Given this list of marker genes TBK1, GPD2, NETO2, TNIP3, BRCA1, NDRG1, DHRS7, NF1 (NCBI Gene Id 646021), IL10RA, FNBP1, ITGB1, AKIP1, DENND10, STT3B, RAB5A, LRP4, KSR2, SOS1, CALHM2, CBFB, KLF11, PARPBP, GLCCI1, FBP1, TAB2, ADAMTS3, IL10RB-DT, PERP, KAT2B, B3GNT5, WBP11, RAB11FIP1 (NCBI Gene Id 80223), PPP1R3D, HIKESHI, DNASE1L1, ERI2, SOCS2, GSTA4, ATP2C1, PPIH, CMTM6, INHBC, CCR6, NME7 (NME/NM23 family member 7), CDKN2B, MARCHF6, PKD2, CISH, PTGR1, PPP4R3A, SYNE3, FCRL3, HIP1, EOGT, CLPTM1L, TOX, KCNK6, TBC1D8, TNFSF13, CRCP, EVI5, ZC2HC1A, TBC1D22B, SEC16A, RDH10, ITGAL, DENND11, PIK3AP1, TMED8, STARD4, MAP4K3, PNPLA8, SAE1, IVNS1ABP, ARAP3, SDF4, UBE2E1, NME9, C2CD2, KCMF1, ADAM19 (NCBI Gene Id 8728), CXorf58, LY75, SGPP1, HYMAI (hydatidiform mole associated and imprinted), KLF9, HSPA1A, ANXA2, GOLIM4, KIT, ZNF788P, ANXA2P2, DPYSL2, TMEM87A, MEOX1, GNG10, CLDND1, PLN, HMGB3, MIR155HG, LAIR2, ZNF80, ATP6V1E1, RIC8B, SRXN1, SERP2, CTTN, ATP1B1, GPR63, VMP1, PLS3, PRF1, SAMSN1, C5, LRRC32, SRGAP2, INPP5F, SMS, CLNK, HLF, IKZF4, IGF2R, CERS5, FRMD6, SIAH2, PCTP, CYBB, PIM1, GINS2, DLG3, HLA-DRB1, MIR21, UTS2, LGALS3, KLHL2, MPST, UBR1, RBMS3, TAOK1, MIB1, MAP7, TOX2, SNX10 (NCBI Gene Id 29887), SPOPL, SERINC1, USP10, PGAM1, RDX, IRS2, CDK6, KSR1, BTNL9, INSL5, AMFR (NCBI Gene Id 267), HS3ST3B1, TMEM62, MED9, TNFRSF18, NABP1, ZPR1, CYP1A1, CHRNA3, IL2RB, TWIST1, ATP1B3, CEP72, MAP3K8, CLGN, MFN2, ENTPD1, NHS, ZBTB20-AS1, AGO4, TENT5C, EPAS1, TRUB1, CREB3L2, UGCG (NCBI Gene Id 7357), FANCL, FAM13A, APLP2, RAD21, HNRNPLL, DHRS3, PPP4R1, MBNL1 (NCBI Gene Id 9850), NEK3 (NCBI Gene Id 4752), CACYBP, PPP3CB, AHR, NFAT5, SLC1A4, PGM2L1, NUDT17, DDX50, DOCK5, TRIB1, MMD, here is a description of the gene set: Human Gene Set: GSE25087_TREG_VS_TCONV_FETUS_UP from publication Mold JE, Venkatasubrahmanyam S, Burt TD, Michaëlsson J, Rivera JM, Galkina SA, Weinberg K, Stoddart CA, McCune JM (PMID 21164017) Genes up-regulated in comparison of fetal regulatory T cell (Treg) versus fetal conventional T cells. We compared differences in fetal and adult T cells by performing whole genome profiling on sort-purified T cells (naïve CD4+ and Treg cells) from human fetal specimens (18-22 gestational weeks) and adult specimens (age 25-40 years old). Fetal and Adult Naïve CD4+ T cells phenotype: CD3+CD4+CD45RA+CCR7+CD27+, Fetal and Adult CD4+CD25+ Treg phenotype: CD3+CD4+CD25bright species: Homo sapiens